Given this list of marker genes IMPDH2, OPA1, NME5, IMPDH1, NME6 (NCBI Gene Id 10201), NME1, NME7, NME2P1, AMPD2, AK3, MFN1, RAN, EFL1, GIMAP7, GNAI3, GTPBP1, LRRK2, RHOQ, NME4, RAB23, ENTPD7, NME3, NME2, AK4, NME9, here is a description of the gene set: studied in species Homo sapiens The chemical reactions and pathways involving GTP, guanosine triphosphate. Human Gene Set: GOBP_GTP_METABOLIC_PROCESS